The following is a description of a gene set: studied in species Homo sapiens Human Gene Set: MIR488_3P from publication Chen Y, Wang X (PMID 31504780) Genes predicted to be targets of miRBase v22 microRNA hsa-miR-488-3p in miRDB v6.0 with MirTarget v4 prediction scores > 80 (high confidence targets)., and this is the list of marker genes: TSC22D1, DCX, IL6ST, EMC4, KRTAP1-3, NRSN2, DLG2, SEC61G, RAB11FIP1 (RAB11 family interacting protein 1), EIF3A, KIAA2013, PXK, AKAP11, SMIM8, ADAM9, PTBP2, PPME1, COL11A1, PRR14L, CLOCK, NADK, ST20-MTHFS, ENAM, ITPRID2, PDE1A, COL4A1, RASGRP3, IGF1, SPDYE1, CENPO (NCBI Gene Id 79172), MTURN, FSCN1 (NCBI Gene Id 6624), SFTPA1, SACS, NFXL1, LOX, TMOD2, NUDCD3, SERINC1, NETO2, RIPOR2, PCDHB16, TENM1, STON1, PHF8, ABI3BP, RNF111, TMEM232, FAM13B, CDK14, TACSTD2, STXBP5, EFNA5, ANKRD13C, CYTIP, TM6SF2 (transmembrane 6 superfamily member 2), RHOT1, SLC4A4, PWWP2A, VAMP7, SLC30A7, ARPIN-AP3S2, PLPP3, EIF2S1, DAZ3, GPATCH2L, PRDM10, TCP1, PKDCC, MAPK1, MAP3K7, MAP2, PAK3, SPDYE5, ZRANB1, EHHADH, JAZF1, SOX5, ZBTB2, PRRC2B, NIPAL3, PPHLN1, DSE, CCNG1, STAM, OLFML1, AEBP2, CXXC4, SMARCC1, EFNB3, CYRIB, RIMKLA, GPSM2, GNAQ, DENND2C, POU3F4, POMC (NCBI Gene Id 5443), PAFAH1B1, PDC, DAZL, CEP170, AFF4, FSTL5, CNOT6L, POLR1D, LCE2D, MTHFS, DAZ2, PPM1G, DENND1B, MMP1, TRMT1L, RSBN1, SLC9A7, SCN2A, NEXMIF, EFCAB12, EXD2, LHFPL3, MACROH2A2, ZDHHC21, DDX4, ARPC5, MYO1B, NDUFA5, FBN1, CADPS2, PCDHB4, AP3S2, FRYL, GORAB, RSPRY1, ZNF136, GRIK1, SH3TC2, NRIP3 (NCBI Gene Id 56675), SPDYE3, MED1, P2RY10, POPDC3, SNX27, LCORL, AKAP13, EFL1, RAD51AP2, RBMS3, SLCO1C1, CTNNA3, CGNL1, SLC4A7, SYNJ1, KLLN, SPDYE6, RNGTT, TRIM58, SP3, RPS6KA6, STAG2, WDFY3, ZNF704, CTSC, PTCH1, KAT6A, STMN4, CAV2, ZIC5, ZNF563, UMAD1, SCAI, GRIA3, NAT8, INTS15, EEF2K, CLEC1A, NUP210, ZNF592, ABHD17B, MXRA5, ZNF195, NOTCH2, PHC3, TTC9C, RAB9B, ARPP19, INO80D, SLC1A2, CHRM5, FBXL5, ELK3, AMMECR1, PPFIA1, NSUN4, CDKL4, DAZ1